The following is a description of a gene set: studied in species Homo sapiens Human Gene Set: GOBP_MITOTIC_DNA_REPLICATION_CHECKPOINT_SIGNALING A signal transduction process that contributes to a mitotic DNA replication checkpoint., and this is the list of marker genes: CLSPN, HUS1, TICRR (NCBI Gene Id 90381), HUS1B, NAE1, ZNF830, TOPBP1, ORC1, DONSON, RAD17, CDC6